The following is a description of a gene set: Reactome Pathway: Keratan sulfate/keratin metabolism This event has been computationally inferred from an event that has been demonstrated in another species.<p>The inference is based on the homology mapping from PANTHER. Briefly, reactions for which all involved PhysicalEntities (in input, output and catalyst) have a mapped orthologue/paralogue (for complexes at least 75% of components must have a mapping) are inferred to the other species. part of: Glycosaminoglycan metabolism studied in species Mus musculus electronically inferred by orthology from the curated human pathway, and this is the list of marker genes: St3gal3, Hexb, B3gnt3, Galns, Glb1l2, Hexa, St3gal4, Glb1l, St3gal2, Glb1l3, Kera, Omd, Chst5, Chst2, Lum, Slc35d2, Acan, B4galt6